Given this list of marker genes P4HB, STAT4, PLCB1, RIPK2, TYK2, IL12RB2, IL12B, SIRPA, CD47, IL12A, JAK2, IL12RB1, here is a description of the gene set: studied in species Homo sapiens Any process that results in a change in state or activity of a cell or an organism (in terms of movement, secretion, enzyme production, gene expression, etc.) as a result of an interleukin-12 stimulus. Human Gene Set: GOBP_RESPONSE_TO_INTERLEUKIN_12